Given this list of marker genes SCN9A, WNK1, NGF, NTRK1, RETREG1, MPV17, ZFHX2, KIF1A, here is a description of the gene set: Painless fractures due to injury An increased tendency to fractures following trauma, with fractures occurring without pain. Human Gene Set: HP_PAINLESS_FRACTURES_DUE_TO_INJURY studied in species Homo sapiens